The following is a description of a gene set: Human Gene Set: GOBP_RETINAL_CONE_CELL_DEVELOPMENT Development of a cone cell, one of the sensory cells in the eye that reacts to the presence of light. Cone cells contain the photopigment iodopsin or cyanopsin and are responsible for photopic (daylight) vision. studied in species Homo sapiens, and this is the list of marker genes: THRB, THY1, DIO3, GNAT2, HCN1, USH1C, PDE6C, CRB2, RORB, RP1, CABP4